Given this list of marker genes GZMA (NCBI Gene Id 3001), CFI, P4HA1, LTA4H (NCBI Gene Id 4048), ILF3, HSPA4L, VEGFA, LDLR, PAM, CTRL, ATP2A2, DAZL, GANAB, DHX30, GLDC, VDR, BCAP31, RABGGTA, DPY19L1, GUSB, MUC1, PRDM1, PTP4A3, NFIB, NCOR2, IRF4, CFHR4, GPAA1, IL10, CASP7, PLPP3, TNFRSF8, ZMYM3, SULT1A2, ADAM15, TPO, ALDH1L1, EIF4A1, VARS1, SRGAP2, IQGAP2, PLOD1, IL2RB, AQP3 (NCBI Gene Id 360), SELPLG, RPN2, GPI, AGPAT2, ALG3, GTF3C1, here is a description of the gene set: Genes up-regulated in AIDS-related primary effusion lymphoma (PEL) samples compared to other tumor subtypes and normal B lymphocytes. species: Homo sapiens Human Gene Set: KLEIN_PRIMARY_EFFUSION_LYMPHOMA_UP AIDS-related primary effusion lymphoma (PEL) is an HIV-associated malignancy characterized by the ability of the tumor cells to specifically home in the serous body cavities. Here we used gene expression profile analysis (about genes) to further define the phenotype of PEL and to investigate the lymphoma relationship to normal B cells and to other tumor subtypes, including non-Hodgkin lymphomas (NHLs) of immunocompetent hosts and AIDS-associated NHL (AIDS-NHL). The results showed that PEL displayed a common gene expression profile that is clearly distinct from all NHLs of immunocompetent hosts and AIDS-NHL subtypes and, in contrast to those, is not related to germinal center (GC) or memory B cells. The gene expression profile of PEL was defined as plasmablastic because it showed features of both immunoblasts identified by Epstein-Barr virus (EBV)-transformed lymphoblastoid cell lines and AIDS immunoblastic lymphoma, and plasma cells, as defined by multiple myeloma cell lines. Finally, our results identify a set of genes specifically expressed in PEL tumor cells. Their expression was validated at the protein level, suggesting their potential pathogenetic and clinical significance. from publication Klein U, Gloghini A, Gaidano G, Chadburn A, Cesarman E, Dalla-Favera R, Carbone A (PMID 12531789)